Given this list of marker genes Ubc, Rps27a, Wwp1 (WW domain containing E3 ubiquitin protein ligase 1), Uba52, Ubb, Erbb4, Uba52rt, Itch, Src, Nedd4, here is a description of the gene set: Mouse Gene Set: REACTOME_DOWNREGULATION_OF_ERBB4_SIGNALING species: Mus musculus Downregulation of ERBB4 signaling